Given this list of marker genes Sost, Akr1c14, Pip5k1c, Sctr, Nde1, Rac3, Lbr, Dlg4, Pak4, Slitrk3, Them4, Gng8, Gas1, Plppr3, Otud1, Epgn, Pgf, Snx3, Npy1r, Tor1aip1, Flrt2, Arhgef38, Bmi1, Mmp3, Rgs18, Akt1s1, Pde5a, Frat1 (NCBI Gene Id 14296), Ppid, Dkk4, Rgs14, Khdrbs1, Msi2, Lck, Thbs4, Plekhg6, Pdgfb, Prkag1, Mob1b, Xcr1, Dock11, Rhoh, Gnb2 (guanine nucleotide binding protein (G protein), beta 2), Mad2l1, Ccdc115, P2ry13, Ptpn6 (protein tyrosine phosphatase, non-receptor type 6), Fkbp1a, Atp6v1c2, Smarca4, Oprm1, Sstr2, Vegfa, Syk, Sstr4, Cxcl12, Lypla1, Gpr17, Gngt2, Armcx3, H2bc13, Cd19, Gopc, Pygo1, Itga2, Nmu, Kremen1, Sry, Ap2s1, Plxnd1, Sox6, Gcg, Ltbp3, Erbb4, Smo, Taar9, Trpc6 (transient receptor potential cation channel, subfamily C, member 6), Mc2r, Cenpn, Gabbr1, Pdk2, Hcrtr2, Csf2, Mtmr4, Agtr2, Ccne1, Nsfl1c, Adcy5, Lpar6, Adgre5, Pcsk5 (NCBI Gene Id 18552), C3ar1, Fzd2 (NCBI Gene Id 57265), Ptpn1, Cct2, Med1, Foxo4, Avpr1b (arginine vasopressin receptor 1B), Mapk14, Ophn1, Hrh4, Mad1l1, Picalm, Igf2, Arhgap11a, Aldh1a3, Mtnr1a, B9d2, Ptpn7, Drd3, Ins2, Zwilch, H2bc27, Tas2r144, Rarg, Pdgfrb, Aplnr, Znrf3, Trat1, Ccl4, Zdhhc9, Psmb5 (NCBI Gene Id 19173), Dock2, Itsn1, Mapk3, Ccr1, Ckap4 (NCBI Gene Id 216197), Tas2r136, Zdhhc7, Rraga, Arhgef33, Cdh5, Nf2, Shb, Psmd7, Cbx4, Letm1, Cenpq, Pag1, Pak3, Htr5a, Ucn, Ptbp1, Ptpn3 (protein tyrosine phosphatase, non-receptor type 3), Col11a2, Itga5, Polr2i (polymerase (RNA) II (DNA directed) polypeptide I), Baiap2l1, Ppp2r5a, Tyk2, Prex1, Pomc, Arhgef10, Gpr161, Sppl2a, H3c13, Npb, Cyba, Rhoj, Pde7b, Cyp26a1, Rnd2, Dusp6, Psma5, Pxn, Foxo6, Prok1, Dvl2, P2ry1, Cysltr1, Csf2rb, Cav1, Ash2l, Strn, Bmp10, Col9a1, Socs3, Mc5r, Khdrbs3, Pth2r, Mta2, Ntsr2, P2ry10, Sdr16c5, Memo1, Wwtr1, Il2ra, Clasp1, Mtmr1, Epn1, Ccr7, Edn2, Hras, Spen, H3c15, Gpr15, Thbs3, Fpr1, Ccl17, Xpo1, Ocrl, Depdc1b, Cdk8, H3c10, Wdr6, Galr2, Pde1b, Fgf10, H3c3, Kng2, Rtn4, Ywhah, Flt4, Cenpu, Mc4r, Vangl1, Nfkbia, Ndc80, Cenpt, Amh, Ranbp10, Alk, Gpsm3, Hmox2, Wnt5b, Prkacb, Dusp5, Rgr, Akr1c21, Camkk1, Dtx1, Irs1 (insulin receptor substrate 1), Thbs2, Gpr20, H4c4, Esr1, Nrtn, Mchr1, Nts, Tlr9, Ndufa5, Gnaz, Dok1, Spop, Adrb3, H4c1, Arhgef39, Tas1r3 (taste receptor, type 1, member 3), Pdk4, Csnk1a1, Itgb5, Myh14, Aldh1a2, Lama4, Ring1, H2bc8, Mc1r, Ryk, Arhgap44, Cby1, Igfals, Mfn2, Oprd1, C5ar1, Cxcl16, Col6a1, Rasal3, Spint1, Cyfip2, Pyy, H2bc3, Rnf111, Tas2r130 (taste receptor, type 2, member 130), Myo19, Wwc1, Mmp14, Notum, Nmur1, Oxgr1, Wnt3, Arhgap18 (NCBI Gene Id 73910), Flot1, Kat5, Swap70, Pdgfd, Rab7 (NCBI Gene Id 19349), Bcl9, Plg, Gata3, Cct7, Hcrtr1, Fuz, Sst, Arhgap26, Pak6, Arhgap12, Cga, Uaca, Fgf5, Gng10, H3f3a, Fes, Mis12, Npffr1, Gfra1, Ar, Crhbp, Vegfb (vascular endothelial growth factor B), Fzd4, Cpd (carboxypeptidase D), Hpn, Glp1r, Cilp, Adh4, Dgki, Wasf1, Tas2r119, Opn4, Psenen, Ccr3, Rho, Tubb2b, Ngef, Fasl, Mapk4, Cd80, Rasgef1a, H4c2 (H4 clustered histone 2), Taar8b, Sox2, Samm50, Il2rb, Fgfr1, Leo1, Pik3ap1, Psmc2, Flt3l, Lamtor2, Acvrl1, Fpr-rs6, Arhgef1, Crk (NCBI Gene Id 12928), Fgf6, H2bc7, Map2k2, Dnmbp, F2rl1, Gng11, Ap2b1, P4hb, Arhgap9, Plin3, H4c11, Dgka, Adra1a, Insl5, Rxfp2, Rgs16, Cd55, Cdc37, Ift57, Sqstm1, Eef1ece2, Phlpp1, Arhgef7, Pcdh7, Ltk, Polr2f, Ptgir, Shc2, Cenpm, Sema4f, Bag4 (NCBI Gene Id 67384), Hhat, Myh10, Phlpp2, Sall4, Ccl6, Nup133, Lin7b, H3c4, Ulk1 (unc-51 like kinase 1), Dhrs9, Dgkh, Rhpn1, Ptprk, Ccdc187 (NCBI Gene Id 329366), Gng4 (guanine nucleotide binding protein (G protein), gamma 4), Tgif1 (TGFB-induced factor homeobox 1), Mapk12, Arap1, Abca1, Tln1, Smad7, Steap3, Fstl3, Uts2b (NCBI Gene Id 224065), Ccr10, Ucn3, Vps26a, Arhgap42, Ift88, Tas2r120, Rbmx, Tuba1c, Rgs8, Lpar5, Btc, Pde10a, Ppp3r1, Sptbn2, Rab4a, Nrg3, Gpbar1, Arpc5, Spp1, Ccl21a, Rab9b, Notch3, Lman1, Wnt9b, Grb2, Emc3, Cxcr5, Stam, Ankle2, Avp, Fas, Dtx4, Fgf15, Rspo1, Dock8, Rgs13, Psma6, Nog (NCBI Gene Id 18121), Alkal2, Mpp7, Daglb, Tnfaip1, Psmc4, Cdc42, Cdc25c, Psmd13, Evl, Mapkapk5, Chrm4, Cnr2, Psap (prosaposin), Birc3, Apbb1ip, Gal, Npff, Gga3, Jup, Gpr35, Grk3, Cxcl3 (C-X-C motif chemokine ligand 3), Klc4, Dusp7, Rasal1, Gper1, Ackr2, Sh3bp1 (NCBI Gene Id 20401), Ubb, Adm2, Khdrbs2, Htr1b, Tpm3, Lamtor4 (late endosomal/lysosomal adaptor, MAPK and MTOR activator 4), Ntsr1, Tubal3, Cdkn1a, Itgb3bp, Ptpn13, Ncoa1, Psma7, Rxfp4, Lat, Shh, Ffar2, Ctsd, Amotl1, Pcp2, Hif1a, Atp6v1e2, Evc (EvC ciliary complex subunit 1), Ndel1, Atp6v1d, Hspe1, Jak3, Prok2, Drd2, Arhgap17, Nmb, Erbb2, Rasgrp4, Gip, Fzd1, Rnf43, H4c8, Ghsr, Rasgrp3, Smad1, Lrp5, Col4a2 (NCBI Gene Id 12827), S1pr3, Tab3, Uts2r, H3c11, Gast, Tas2r126, Stk10, Galr3, Cbfb, Trim27, Shc1, Ubxn11, Mapk11 (NCBI Gene Id 19094), Taar1, Crhr1, Cenpa (NCBI Gene Id 12615), Cxcr3 (C-X-C motif chemokine receptor 3), Ccl20, Ramp3, Fyn, Rnf146, Casr, Arhgef17 (Rho guanine nucleotide exchange factor 17), Otud3, Ccl21e, Flrt1, Hcrt, Pth2, Flot2, Rapgef2, Pdha1, Klb, Gdf2, Opn3, Sgk1, Hecw1, Wnt7a, Pdpk1, Ackr4, Akr1c13, Racgap1, Tuba4a, Arhgap40 (Rho GTPase activating protein 40), Usp21, Map2k1 (mitogen-activated protein kinase kinase 1), Ucn2, Ins1, Cd28, Tuba1b, Grin1, Smurf2, Rasa1, Cltb, Pde1c, F2, Ngf, Pik3cb, Atp6v1g3, Tuba8, Trpc7, Il33, Rgs9, Dvl1, Lpar2, Axin2 (NCBI Gene Id 12006), Rtkn, Ptger2, Fstl1, Fgf2, Kit, Ptpn18, Rhot2, Rictor, Hgfac, Sct, Hc (NCBI Gene Id 15139), Frat2, Fzd6, Fpr-rs3, Oxt, Pnoc, Lamtor1, Fgf8, Col2a1, Ihh, Emd, Pygo2, Tnf, Prkch, Tagap, Kremen2, Psma4, Epha2, Kif5b (kinesin family member 5B), Arhgap19, Bdkrb2, Actr3, Bcap31, Arpc2, Cckbr, Cmklr1, Cnksr1, Chd8, Ccl3, Gcgr, Fam13a, Pfn2, Lgr5, Wnt10a, Smpd2, Ccl19, Ska1, Tas2r139, Mapk7, Ranbp9, Atp1b4 (ATPase Na+/K+ transporting, beta 4 polypeptide), Gprc6a, Gna13, Tec, Prkaca, Trhr, Oprl1, Omg, Ghrh, Adrb1, Tradd, Fgf20, Grem2, Tcf7l2, Tuba1a, Ptgdr, Numb, Cdkn1b, Ndufs3, Dlg3, Eif4ebp1, Fzd7, Mrtfa, Mks1, Grpr, Tcirg1, Septin7, Pik3c3, Glp2r (glucagon-like peptide 2 receptor), Faf2, Bdkrb1, Fam83b, Grp, Grm4, Aaas, Grk6 (G protein-coupled receptor kinase 6), Rxfp3, Fpr-rs4, Tacr1, Lrrc1, Acvr2a, Tas2r105, Drd5, Ctnnb1, Wwp2, Gnao1, Tas2r135, Dusp2, Psma3, Cdon, Atp6v0d1, Wdr35, Hspb1, H4c14, Yap1, Camkk2, Rnd1, Phc1, Noxa1, Flt1, Ccl21f, Nckipsd, Gna14, Ptpn2, Rgl3, Pebp1, Fgf23, Tnks2, Arhgap10, Tcf7l1, Pip4k2c, Ptn, Nup85, Il3, Ptpn12, Psmd12, Hcar1, Aurkb, Drd4, Grap2, Npy2r, Arf6, Phb1, Tab1, Vegfd, Wnt9a, Inhbb, Rasa4, Elf3, Slitrk5, Grin2d, Fam13b, Myl9, Ccl5 (C-C motif chemokine ligand 5), Hrh3, Cdk5, Tacr2, Ikbkb, Cdk4, Ccl9, Optn, Rgs7, Cxcr6 (C-X-C motif chemokine receptor 6), Wnt10b, Wnt8b, Prkar2b, Col6a5, Il2rg, Ttc21b, Pfn1, Arrb2, Icos, Klc3, Gab1, Plk1, Qrfprl, Vrk3 (NCBI Gene Id 101568), Ep300, S1pr5, Aldh8a1, Bcl9l, Fam83a, Rrh, Dnajb1, Dkk2, Acbd5, Il1rl1, Prokr1, Stard13, Lpar4, Ksr2, Ccl12 (NCBI Gene Id 20293), Rdh10, Chrdl1, Sstr1, Chrm2, Usp4, Gdnf, Farp1, Gnb5, Gipr (gastric inhibitory polypeptide receptor), Akap12, Cx3cr1, Itga2b, Rgs2, Frs2, Gtf2f2, Atp6v0a4, Dync1li2, Ghrhr, Chrm3, Wnt3a, H2bc22, Brap, Rhov, Gnrhr, Nefl, Tac2, Wnt7b, Gna12, Rxrb, Spred3, Dgkb, Lamtor5, Atp6v0c, Ier3, Hebp1, C5ar2 (NCBI Gene Id 319430), Vegfc, Tas2r121, Arhgap25, Actr2, Zfyve16, Rac2, Rps6kb1, Rragc, Polr2b, Fgfbp3, Pik3r2, Sstr3, Nlk, Fgf4, Fpr-rs7, Gpr83, H4c17, Stard8, Cenps, Egr2, Polr2c, Hgf, P2ry2, Cort, Cct6a, Gphb5, Fermt2, Mag, Mst1, Wdr83, Tas2r138 (NCBI Gene Id 387513), Rspo3, Psma2, Diaph2, Il5ra, Atp6v0a1, H2bc15, Tab2, Cul1, H4c6, Atp6v0e, Vcp, Cav2, Ptpra, Rgs6, Il5, Kntc1, Cxcr4, Rgl1, Rbbp4, Zdhhc21 (NCBI Gene Id 68268), Pth1r, Htr2c, Gpr84, Gpr176, Il2 (interleukin 2), Tns4, Sfn, Adra2a, Cma1, Pea15a, Wnt8a, Prkcg, Atp6v1a, Ncf2, Vip, Arhgdib, Tgfa, Psmb7, Hrh1, Fzd8, Polr2l, Rbbp7 (retinoblastoma binding protein 7, chromatin remodeling factor), Sel1l, Lingo1, Galr1, Klhl12, Shoc2, Irs2, Polr2a, Adora2a, Ddx4, H2bc9, Avpr1a, Cbl, Wnt1, Rack1, Cbx6, H3c7, Arhgef37, Inhba, Irak1, Axin1, Tnfaip3, Ntf5, H2bc11, Tas2r108, Matk, Ccl11, Fgf1, Csk, Ffar3, Rhob, Tgfb1, Mapk8, Wnt4, Fabp5, Sos2, Adra2c, Akr1c18, Gfra2, Fgd2, Pik3r5, Chrm1, Pgrmc2, Bambi, Gpnmb, Psmd6, Lpar3, Adcyap1, Dock5, Tnfrsf1a, Crhr2, Arhgap22, Arhgap45, Cenpe (centromere protein E), Grk5, Dynll1, Prkar1b, Kdm1a, Fgfbp1, Il6, Tmem87a, Ncor2, Cysltr2, P2ry4, Kel, Gmip, H2bc12, Ncf1, Tas1r2, Arhgap8, Cbx2, H4c3, Smad6, Rara, Cck, H2bc1, Sucnr1, Rps27a, Atp6v1f, Sh3gl3, Cxcl10, Psmc5, Nr4a1, Opn5, S1pr4, Psmc3, Wnt2b, Erlec1, Gpr4, Arhgef15, Gpr150, Taar8c, Ywhae, Cdk1, Ccr8, Lmnb1, Muc13, Cyld, Gnb3, Dlat, Bcar1, Fgf16, Psmc6, Esr2, Vav1, Nms, Myd88, Epo, Twf1, Npsr1, Spc24, Gtf2f1, Gja1, Dsg1a, Gps2, H3c8, Carm1, Mc3r, Fadd, Gng3, Kitl, Baiap2l2, Ppp5c, Sppl2b, Seh1l, Gnat1, Gpr132, Tas2r131, Sox4, Taar5, Pip5k1a, Adcy7, H4c12, Ezh2, Cnr1, Fgg, Ngfr, Cbx8, Wnt11, Evc2, Amer1, Gpr183, Mbd3, Scmh1, Ap2m1, Ccl28, Tubb4a, Kl, Ret, Yes1 (NCBI Gene Id 22612), Vangl2, Scfd1, Ktn1, Adra2b, Kiss1, Tcf7 (transcription factor 7, T cell specific), Psmc1, Camk2b, Taar3, Bad, Arhgef10l, Tbl1x, Gpr143, Ift172, Dusp16, Tuba3b, Rps6kb2, C3, Ppp1r14a, Dagla, H2ac1, Casp8, Traf1, Irs4, Fam169a, Uts2, Tfdp1, Arpc4, Gli3, Col24a1 (collagen, type XXIV, alpha 1), Pf4, Smad9, Timp1, Ube2d1, Dll4, Rasgrp1, Adm, Cxcr2, Fgd5, Spata2, Eps15l1, Col5a3, Iapp, Arhgap28, Polr2k, Noxo1, Spry1, Cxcr1, Tas2r118, Hrh2, Txnl1, Lats1, Fmnl2, Dusp9, Mib2, Muc20, Brs3, Opn1sw, Sptbn4, Epor, Atp6ap1, Htr6, Dkk1, Sox7, Stat5a, Myl6, Gipc1, Dhrs4, Crabp1, Grap, Psmd1, Pde2a, Stat5b, Ulk3, Avpr2, Cxcl2, Fshr, Rps6ka5 (NCBI Gene Id 73086), Axl, Prokr2, Csnk2b, Tubb4b, Gng5, Mmp2, Cdh1, Pld2, Fgfrl1, Fnta, Htr1f, Ltb4r1, Ccl7, Plppr5, Ralgds, Ckb, Basp1, Npw, Kidins220, Trak1, Ptprf, Tsc1, Psen1, Cckar, Vrk2, Fgf17, Polr2e, Egfr, Smad3, Usf2, Nudc, Foxa1, Vim, Gpr27, Psmb4, Rarb, Areg, Oxtr (oxytocin receptor), Adcy8, Ptk2, Gnai1, Ppp2r5d, Hcar2, Itga3, Trip10, Sox17, Nfkb1, Prlhr, H3c2, Tubb6, Mta1, Pard3, Vhl, Ncam1 (neural cell adhesion molecule 1), Pde8a, Npy4r, Rhou, Cxcl9, Ccr4, Tshr, Pde6g, Mdk, Rps6, Psmb6, Psma1, Nox3, Tert, Akr1c6, Lats2, Fkbp4, Akr1c20, Pkn1, Itgb8, H4c18, Tbxa2r, Artn, Esyt1 (NCBI Gene Id 23943), Zfp512b, Fgd1, Gngt1 (guanine nucleotide binding protein (G protein), gamma transducing activity polypeptide 1), Wnt16, Sh2b3, Vps35, Gpr65, Prkca, Ppy, Plcb3, Htr1a, Ptger1, Gfod1, Maf1, Ap2a1, H3c1, Fgf22, Gnat3, Arhgef12, Acvr1c, Il6ra, Arhgdig, Casp9, Rdh5, Col6a6 (collagen, type VI, alpha 6), Rxrg, Dvl3, Ppp2r5b, Penk, Ltbp2, Ccr6, Csnk1e, Clip3, Kif2b, Cited1, Atp6v1g2, Tmod3, F2rl3, Ffar1, Prkag3, Bcl2l1, Gng7, Dld, Htr7, Shc3, Rela, Ccnd1, Arhgap15, Nedd8, Tas2r107, Arhgap33, Arhgef3, Tas2r137, Abhd17c, Ppp2r1b, Ppp1ca, Calm1, Cdc14a, Edn3, Plekhg3, Gtf2a1, Cyp26b1, Spry2, Gpsm2, Dlc1, Edn1, Wasf3, Fgf7, Rgs1, Vipr1, Dhrs3, Htr4, Dtx2, Actc1, Snw1, Bdnf, Fshb, Vipr2, Cnksr2, Rheb, Ece1, H4c9, Ptger4, Casp3, Qrfp, Grin2b, Gpr68, Tbp, Plppr1, Ednrb, Gpha2, Rgs4, Ptgdr2, Kmt2b, Trh, Dll1, Casp2, Atp6v0e2, Kiss1r, Cxcl1, Mcam, Pdgfa, Rln3, Nmur2, Mmp7, Men1, Mapk13, Smurf1 (NCBI Gene Id 75788), H3c6, Hdac3, Pde6b, Kif2c, here is a description of the gene set: Reactome Pathway: Signal Transduction electronically inferred by orthology from the curated human pathway This event has been computationally inferred from an event that has been demonstrated in another species.<p>The inference is based on the homology mapping from PANTHER. Briefly, reactions for which all involved PhysicalEntities (in input, output and catalyst) have a mapped orthologue/paralogue (for complexes at least 75% of components must have a mapping) are inferred to the other species. species: Mus musculus